Given this list of marker genes PSMB4, PSMD3, PSMD14, PSMB3, PSMB7, UBB, PSMA4, PSMA1, ATM, RPS27A, PSMD13, TP53, PHF20, PSMB5, PSMA5, PSMD1, PSMA2, PSMD2, UBC, PSMC5, PSMC3, PSMC2, UBA52, PSMB6, MDM2, PSMA7, COP1, PSMC4, PSMB2, PSMC1, PSMD7, PSMB1, CHEK2, PSMA6, PSMA3, PSMD6, PSMD8, ADRM1, SEM1, CDKN2A, PSMD11, PSMD12, MDM4, PSMC6, here is a description of the gene set: Reactome Pathway: Stabilization of p53 part of: p53-Dependent G1 DNA Damage Response Later studies pin-pointed that a single serine (Ser-15) was phosphorylated by ATM and phosphorylation of Ser-15 was rapidly-induced in IR-treated cells and this response was ATM-dependent. ATM also regulates the phosphorylation of p53 at other sites, especially Ser-20, by activating other serine/threonine kinases in response to IR. Phosphorylation of p53 at Ser-20 interferes with p53-MDM2 interaction. MDM2 is transcriptionally activated by p53 and is a negative regulator of p53 that targets it for degradation. In addition modification of MDM2 by ATM also affects p53 stabilization. species: Homo sapiens